Given this list of marker genes CUL1, NOTCH1, SKP1, RBX1, FBXW7, here is a description of the gene set: part of: FBXW7 Mutants and NOTCH1 in Cancer Reactome Pathway: Loss of Function of FBXW7 in Cancer and NOTCH1 Signaling Loss of function mutations found in FBXW7 in T-cell acute lymphoblastic leukemia are predominantly dominant negative missense mutations that target one of the three highly conserved arginine residues in the WD repeats of FBXW7. These three arginine residues are part of the FBXW7 substrate binding pocket and each one of them contacts the phosphorylated threonine residue in the conserved substrate phosphodegron region. Specifically, FBXW7 interacts with the PEST domain of NOTCH1 upon phosphorylation of the PEST domain by CDK8. FBXW7 mutants are therefore unable to bind and promote ubiquitination of the NOTCH1 intracellular domain (NICD1), leading to prolonged NICD1 transcriptional activity. species: Homo sapiens